Given this list of marker genes RBPJ, RWDD1, TGFBI, IKBKE, NDUFS6, TMEM14C, GSDMD, RGS3, NRP2, SLC30A6, CNIH4, CDK5RAP3, PPRC1, CLUH, SIGLEC7, UGDH, PHLDA1, MALT1, ERH, ZNF593, ZNRF4, COL18A1 (collagen type XVIII alpha 1 chain), PEX16 (peroxisomal biogenesis factor 16), DOHH, TRMT2A, ALPG, FAM20C, SEC22B, EFHB, TIMD4, TULP1, TMEM176B, SRSF1, SEPTIN11, ERLIN2, XPNPEP1, CMTM7, BST1, GLB1 (galactosidase beta 1), TUBA1B, ZNRD2, DNAJA3, PPP1R21, EIF3B, IGF2R (insulin like growth factor 2 receptor), UST, TRDMT1, ENDOG, HAGHL, PRDX2, SMS, CTSZ, DOCK7, SPG7, ERLIN1, KLF16, TREM1, MLLT6, MIR22HG, COX11 (cytochrome c oxidase copper chaperone COX11), NUDT2, AKR1B15, FAM98B, GRK5, GRB2, HSPA1A (heat shock protein family A (Hsp70) member 1A), LAGE3, ALG9, SNX10, TXN2, MED11 (mediator complex subunit 11, NCBI Gene Id 400569), PC, EMC4, JPT2, NT5C3B, PITPNA, TYSND1, OST4, AFP, ADK, HSPD1, MECR, HYPK, SAMSN1, PARL, TRIM13, FUBP1, HSD17B12, CFP, S100A10, MMP19, SPRED2, TMEM176A, ABHD11, LSM6, DIAPH2, CPD, DUSP1, EIF1AX, ADRB3, P4HA2, HSD17B7, SNRNP35, PLPP5, NFKBIA, PGS1, PSMC2, F10, RNF14, PCDH7, MRPL11, SRXN1, JUNB, LRRC59, ANAPC16, GMPPB, ANTXR1, CHID1, NFU1, PLEKHM3, EPB41L3, TNFSF9, CXCL2 (NCBI Gene Id 2920), CD274, FBL, ARMC1, YJU2, ARHGDIA, PROCR, PRELID3B, ATP1A1, RCC1, NIF3L1, CSF2RB, ZSWIM7, TMEM268, FASTKD3, VPS28, SMYD2, PSMB10, AGPAT4, IL1RN (interleukin 1 receptor antagonist), FDFT1, EBI3, MAFF, PSMC5, RAC2, GTF3C5, DNAJB11, BIRC3, CAD, TAL2, TLR2, NSUN7, TMCC1, ODC1, HACD3, PLEKHA8, ATP6V1H, RASSF4, DYNLL1, VCL (NCBI Gene Id 7414), BLVRB, EIF2B3, SLC18A3, LTBR, PPME1, TBC1D13, STIP1, SLC25A10, INTS11, CYB5B, HSPA9, DIS3, IL13RA1, SLC35B1, SUMO3, U2AF1, CAV2, CCDC103, CLEC4A, PIK3R6, UBE2F, NUP93, VARS1, CIB1, WDR18, CYSLTR1, POLR2D, ARHGDIB, PTPN9, SEC13, GADD45A (NCBI Gene Id 1647), PSMB7, DLST, SDHB, AIF1 (allograft inflammatory factor 1), DDX39A, LAT2, MOGS, here is a description of the gene set: from publication Hervas-Stubbs S, Riezu-Boj JI, Gonzalez I, Mancheño U, Dubrot J, Azpilicueta A, Gabari I, Palazon A, Aranguren A, Ruiz J, Prieto J, Larrea E, Melero I (PMID 21108462) Human Gene Set: GSE17301_CTRL_VS_48H_ACD3_ACD28_IFNA2_STIM_CD8_TCELL_UP Genes up-regulated in CD8 T cells: control versus stimulated by IFNA2 and activated by anti-CD3 and anti-CD28. IFN alpha mediated gene expression pattern. The effect of IFN alpha on human CD8 T cells responding to antigen (signal 1) and costimulatory signals (signal 2) provided by beads coated with anti-CD3 and anti-CD28 mAbs. This analysis examined the effects of IFN alpha on human CD8 T cells responding to antigen (signal 1) and costimulatory signals (signal 2) provided by beads coated with anti-CD3 and anti-CD28 mAbs. Magnetically sorted untouched CD8+CD45R0- T cells from three different donors were unstimulated or stimulated with IFNa2b or with anti-CD3/CD28 Beads alone or along with IFNa2b or IFNa5 for 48 hours. Individual mRNA samples were analyzed using HG-U133A 2.0 array gene chips. studied in species Homo sapiens